The following is a description of a gene set: Widely spaced primary teeth species: Homo sapiens Human Gene Set: HP_WIDELY_SPACED_PRIMARY_TEETH Increased space between the primary teeth. Note this phenotype should be distinguished from increased space due purely to microdontia., and this is the list of marker genes: WNT10A (Wnt family member 10A), ERCC4, ERCC6, ERCC8, RNF113A, ERCC1 (ERCC excision repair 1, endonuclease non-catalytic subunit)